Given this list of marker genes Acad8, Bcat1, Acadsb, Bckdk, Hibadh, Bckdhb, Mccc2 (methylcrotonoyl-Coenzyme A carboxylase 2 (beta)), Dld, Bcat2, here is a description of the gene set: Reactome Pathway: Branched-chain amino acid catabolism part of: Metabolism of amino acids and derivatives electronically inferred by orthology from the curated human pathway This event has been computationally inferred from an event that has been demonstrated in another species.<p>The inference is based on the homology mapping from PANTHER. Briefly, reactions for which all involved PhysicalEntities (in input, output and catalyst) have a mapped orthologue/paralogue (for complexes at least 75% of components must have a mapping) are inferred to the other species. species: Mus musculus